The following is a description of a gene set: species: Homo sapiens from publication Schaefer CF, Anthony K, Krupa S, Buchoff J, Day M, Hannay T, Buetow KH (PMID 18832364) IL1-mediated signaling events Human Gene Set: PID_IL1_PATHWAY, and this is the list of marker genes: ERC1, IRAK1, TOLLIP, PIK3R1, TICAM2, MAP3K3, PIK3CA, SQSTM1, TAB2, CHUK, TRAF6, CASP1, IKBKG, JUN, TAB1, PRKCZ (protein kinase C zeta), IRAK3, RELA, IL1R2, IRAK4, IL1RN, UBE2N, IL1B, UBE2V1, IL1A, MAPK8, PRKCI, IKBKB, IL1R1, MAP3K7, MAP2K6, NFKB1, MYD88, IL1RAP